The following is a description of a gene set: Human Gene Set: MIR5585_5P species: Homo sapiens from publication Chen Y, Wang X (PMID 31504780) Genes predicted to be targets of miRBase v22 microRNA hsa-miR-5585-5p in miRDB v6.0 with MirTarget v4 prediction scores > 80 (high confidence targets)., and this is the list of marker genes: SUMO3, PPP1R14C, TTPAL, FAM216A, SAP130, B3GALNT1, TFDP3, CAPN6, AMDHD1, RAB6A, GNAS, XYLT1, MCM9, SASS6, CLNS1A, LRAT, SLC24A2, MED13L, LMAN1, RP1, ARHGAP5, FAN1, NRK, ZNF644, ILDR2, CLN8, FBXL5, TBC1D3F, BCAT1, FAM24A, AP1S2, TBC1D3K, TBC1D3I, ZNF217, TOMM22, HARS1, PAFAH1B2, RB1CC1, ROPN1, GRIA3, TBC1D3, LPCAT1, NCAN, SNRK, STK39, PCCA (propionyl-CoA carboxylase subunit alpha), SEPTIN6, TOX, SMIM8, TTC39B, SLITRK6, MAPK1, IRX2, TFPI, GABRB1, RAB6D (NCBI Gene Id 150786), FBXO41, SLC10A2, UST, UNC45B, AGO3, XBP1, MOB1A, TBC1D3D, SLC25A6, VCF1, TBC1D3C, FLG2, CFTR (CF transmembrane conductance regulator), KDM2B, PKN2 (NCBI Gene Id 5586), PI4K2B, FKBP10, MIP, TBC1D3L, HMGCS1, ATP1A1, ARPP19 (cAMP regulated phosphoprotein 19), FAM13B, TBC1D3B, ROBO2, UBE3B, SLC20A2, SLC11A2, CARD8, CNTN3, TVP23C, SNIP1, PDE8B, PHF20L1, CYB5D1, GRM7, RTKN2, RABL3, ITGB8, KDM5D, ENPEP, AUH, FOXO1, GTPBP10, CNEP1R1, FGF7, MR1, EBF3, PIK3AP1, ATPSCKMT, ERCC6L2, RAB12, ZNF407, ARMH4, CFLAR, WWP2, TTC39A, ACAD11, CILP, SRR, PZP, DNAJC12, ZNF615, ANTXR2, CTSO, BSN, TBC1D3H, CA8, ADRA1B, PURB, VPS53, C1GALT1C1L, DDHD1, DISC1, APOLD1, YME1L1, SUCNR1, RAB6C, EIF4E, PDCD10, CLINT1, RPRD1B